Given this list of marker genes GLI3, SOX1, SUFU, DBX1, GLI2, DMRT3, LHX3, here is a description of the gene set: species: Homo sapiens Human Gene Set: GOBP_CELL_FATE_SPECIFICATION_INVOLVED_IN_PATTERN_SPECIFICATION The process involved in the specification of the identity of a cell in a field of cells that is being instructed as to how to differentiate. Once specification has taken place, that cell will be committed to differentiate down a specific pathway if left in its normal environment.